The following is a description of a gene set: Mouse Gene Set: GOCC_CORE_MEDIATOR_COMPLEX studied in species Mus musculus A protein complex that interacts with the carboxy-terminal domain of the largest subunit of RNA polymerase II and plays an active role in transducing the signal from a transcription factor to the transcriptional machinery. The core mediator complex has a stimulatory effect on basal transcription, and contains most of the same subdomains as the larger form of mediator complex -- a head domain comprising proteins known in Saccharomyces as Srb2, -4, and -5, Med6, -8, and -11, and Rox3 proteins; a middle domain comprising Med1, -4, and -7, Nut1 and -2, Cse2, Rgr1, Soh1, and Srb7 proteins; and a tail consisting of Gal11p, Med2p, Pgd1p, and Sin4p -- but lacks the regulatory subcomplex comprising Ssn2, -3, and -8, and Srb8 proteins. Metazoan core mediator complexes have similar modular structures and include homologs of yeast Srb and Med proteins., and this is the list of marker genes: Med18, Med15, Med27, Med10, Med1, Med11, Med4, Med25, Med24, Med6, Med19, Med8, Med20, Med7, Med14, Med9, Med30, Med16, Med17, Med31, Med26, Med21, Med29, Med22, Med23, Med28